Given this list of marker genes Pcsk4, Spaca4, Fam170b, Cd46, Flot2, Ift88, Hyal5 (NCBI Gene Id 74468), Izumo3, Cfap65, Tmem190, Cav2, Slc2a3, Abhd2, Tex101, Spata31 (spermatogenesis associated 31), Ace3, Rnd2, Dcst1, Spaca6, Eqtn, Bsg, Sun1, Serpina5, Creb3l4, Rab6a, Mfge8, Glipr1l1, Hyal3, Pkdrej, Ccdc136, Pla1a, Izumo1, Tekt3, Vps13b, Atp8b5, Tmem95, Spaca3, Acrbp, Zp3r, Tmem225, Atp8b3, Usp8, Cav1 (NCBI Gene Id 12389), Trip11, Dcst2, Cylc1, Zpbp, Spaca1, here is a description of the gene set: The membrane that surrounds the acrosomal lumen. The acrosome is a special type of lysosome in the head of a spermatozoon that contains acid hydrolases and is concerned with the breakdown of the outer membrane of the ovum during fertilization. Mouse Gene Set: GOCC_ACROSOMAL_MEMBRANE studied in species Mus musculus